The following is a description of a gene set: studied in species Mus musculus The series of molecular signals initiated by an extracellular ligand binding to an activin receptor on the surface of a target cell, and ending with the regulation of a downstream cellular process, e.g. transcription. Mouse Gene Set: GOBP_ACTIVIN_RECEPTOR_SIGNALING_PATHWAY, and this is the list of marker genes: Csnk2b, Igsf1, Tgfbr2 (transforming growth factor, beta receptor II), Cripto, Cer1, Inhba, Ski, Gdf2, Hjv, Acvr2b, Fgf10, Smurf1, Nog, Smad7, Gdf11 (NCBI Gene Id 14561), Dmrt1, Bmp10, Lemd3, Fstl3, Fgf9, Acvr2a, Smad4, Smad3, Tgif1, Men1, Cited2, Dact1, Zc3h3, Gdf6, Lefty1, Synj2bp, Acvr1c, Smad6, Bmpr1a, Mir210, Bmpr1b, Tgfbr1 (transforming growth factor, beta receptor I), Nodal, Bmpr2, Fst, Cfc1, Fkbp1a, Zic2, Dact2, Acvrl1, Smad2, Tgif2, Amhr2, Acvr1, Inhbb, Acvr1b, Magi2, Gdf7, Dand5